The following is a description of a gene set: Targetable kinases differentially expressed between PDX and donor tumors from nine ovarian cancer patients. from publication Liu Y, Chanana P, Davila JI, Hou X, Zanfagnin V, McGehee CD, Goode EL, Polley EC, Haluska P, Weroha SJ, Wang C (PMID 31004097) A bioinformatics pipeline to separate donor tumor and mouse stroma transcriptome profiles was devised and tested. To examine the molecular fidelity of PDX versus donor tumors, the authors compared mRNA differences between paired PDX-donor tumors from nine ovarian cancer patients. Human Gene Set: LIU_OVARIAN_CANCER_TUMORS_AND_XENOGRAFTS_KINASES_DN species: Homo sapiens, and this is the list of marker genes: PDGFRA, DDR2, HCK, KDR, DCLK1, JAK2, STK32B, PIK3CG, PDGFRB, NTRK2, AKT3, ACVRL1 (NCBI Gene Id 94), MAPK11, CAMK4, FLT1, PRKG1, LRRK2, JAK3, PRKD1, PRKACB, TEK (TEK receptor tyrosine kinase), PLK3, AXL, BTK, CAMK2D, IRAK3, ITK, STK17B, CSF1R, LCK, TIE1, FLT4, FGR, EPHA3